The following is a description of a gene set: Human Gene Set: LOCKWOOD_AMPLIFIED_IN_LUNG_CANCER Chromosomal translocation is the best-characterized genetic mechanism for oncogene activation. However, there are documented examples of activation by alternate mechanisms, for example gene dosage increase, though its prevalence is unclear. Here, we answered the fundamental question of the contribution of DNA amplification as a molecular mechanism driving oncogenesis. Comparing 104 cancer lines representing diverse tissue origins identified genes residing in amplification 'hotspots' and discovered an unexpected frequency of genes activated by this mechanism. The 3431 amplicons identified represent approximately 10 per hematological and approximately 36 per epithelial cancer genome. Many recurrently amplified oncogenes were previously known to be activated only by disease-specific translocations. The 135 hotspots identified contain 538 unique genes and are enriched for proliferation, apoptosis and linage-dependency genes, reflecting functions advantageous to tumor growth. Integrating gene dosage with expression data validated the downstream impact of the novel amplification events in both cell lines and clinical samples. For example, multiple downstream components of the EGFR-family-signaling pathway, including CDK5, AKT1 and SHC1, are overexpressed as a direct result of gene amplification in lung cancer. Our findings suggest that amplification is far more common a mechanism of oncogene activation than previously believed and that specific regions of the genome are hotspots of amplification. studied in species Homo sapiens Overexpressed genes with amplified copy number across 27 non-small cell lung cancer (NSCLC) cell lines. from publication Lockwood WW, Chari R, Coe BP, Girard L, Macaulay C, Lam S, Gazdar AF, Minna JD, Lam WL (PMID 18391978), and this is the list of marker genes: DYNLT2B, TUFT1, MRPL23, EEF1AKMT4, JTB (jumping translocation breakpoint), TES, CLCN2 (chloride voltage-gated channel 2), CCDC85C, TENT4A, MRPL11, CAPZA2, MRPL36, NKX2-1, PC, ATF6, CD84, JPH1, CTSK, BCL11B, USP13, ZSCAN21, INPPL1, CAV2, PPP1R3D, ARHGAP9, CCT6A, CERS2, STRN3, FASTKD3, TSFM, S100A11, ANAPC15, PYGO2, NUDT1, NAT10, PSMB4, POLR2J, SEC23A, PPFIA1, HYOU1, TMEM191A, PI4KB, LPCAT1, PUF60, CFL2, PCYT1A, C14orf132, RTN4R, SNAPIN, SKIL (SKI like proto-oncogene), ABCF2, NAXE, GPAA1, CCDC107 (NCBI Gene Id 203260), IGSF8, FAM131A, NDUFS2, RIT1, CTSF, JTB-DT, TDRKH, MET, TPM3, POLD4, APIP, PPP2R3C, DUSP12, B4GALT3 (beta-1,4-galactosyltransferase 3), NUMA1, RAD23A, ILF2, SIVA1, CAT, PNN, TFRC, SNX6, SRD5A1, ALKBH4, SDHA, GEMIN2, CORO1B, PPP1CA, SRP54 (signal recognition particle 54), NPR1, AGPAT1, SETDB1, METTL1, MRPS17, ZNF74, USP21, MYNN, MRM2, SLC39A1, GNS, ZNF277, DVL3, SHC1, NIPSNAP2, DEDD, LANCL2, CCS, MIPOL1, PBX1, NDUFS6, KCNH2, SEC62, NFKBIA, AIP, COPS6, S100A6, CDK5, GCDH, GFUS, DPP3, RBM4, AP4S1, SLC12A7, DDIT3, CPSF1, LY6E, CALM1, CD44, SEC61G, TRIM44 (tripartite motif containing 44), EIF4G1, S100A13, MFN1, MCM7, FAM177A1, PRCC, PPP1R16A, SSR2, FJX1, CCDC127 (NCBI Gene Id 133957), KDM2A, CCT5, FIGNL1, FADD, PIP5K1A, RPS27, TAF6, HAX1, ARHGAP5, SNAP29, YY1, PLD1, OTULIN, ABCC5, VEGFA, CDK4, ARNT, AKT1, SMIM12, MBIP, PDCD6 (NCBI Gene Id 206269), P2RY6, TARS1, PHC3 (NCBI Gene Id 80012), TFDP1, PI4KA, LAMTOR1, EAPP, FKBP9, CUL2 (NCBI Gene Id 8453), COCH, DENND4B, MBD6, MANBAL, NDUFB5, YKT6, MAGEF1, MAFB, OPA1, BAZ1A, ATP6V1C1, C5orf22, OTULINL, TMEM134, LSM8, CRKL, NRDE2 (NRDE-2, necessary for RNA interference, domain containing), GNB2, TECPR2, HDGF, BLCAP, MAF1, PRORP, MED15, ADAR, SLC4A2, MTRR, POGZ, CLPTM1L, AP2M1, NUBP1, PMF1, ARHGEF11, TTC8, POLR2H, DHCR7, PAX9, PMVK, MYC, PIK3CA, DAP, CKS1B, RMI2, EGFR, AGO2, DDX10, PARD3, MRPL9, ZNF3, FASTK, KLC1, PCID2